The following is a description of a gene set: Genes down-regulated in comparison of unstimulated CD8 T cells at 48 h versus CD8 T cells at 48 h after stimulation with IL12. species: Homo sapiens Human Gene Set: GSE15930_STIM_VS_STIM_AND_IL12_48H_CD8_T_CELL_DN from publication Agarwal P, Raghavan A, Nandiwada SL, Curtsinger JM, Bohjanen PR, Mueller DL, Mescher MF (PMID 19592655) Differentiation of naive CD8 T cells into cytotoxic effector cells requires three distinct signals- antigen (signal 1), costimulation -B7-1 (signal 2) and cytokine, either interleukin-12 or interferon-a/b (signal 3). Interaction of naive CD8 T cells with antigen and B7-1 programs cell division and proliferation whereas the presence of cytokines- IL-12 or IFNa/b promote survival, differentiation and memory establishment. In the absence of signal 3, the cells interacting with antigen/B7-1 undergo tolerance induction. The objective of this study was to elucidate the mechanisms how the provision of signal 3 promotes differentiation and averts tolerance induction in CD8 T cells. Trichostatin A is a pharmacological agent that inhibits histone deacetylase activity, hence regulating chromatin structure and gene expression and differentiation in many cell types. Gene signature profiles of IL-12, IFNa/b and trichostatin A stimulated cells were compared to elucidate the molecular mechanisms of gene regulation. Oligonucleotide microarray analysis is carried out to determine the extent and molecular nature of the CD8 T cell differentiation program induced by IL-12 or IFNa/b in concert with antigen and B7-1 signal., and this is the list of marker genes: TNFSF10, ADRB2, ERCC4, GTF2F2, EPS8, TACSTD2, SOCS3, HRAS, GP1BA, HOPX, RAN, ANXA10, POLD2, SURF1, TMEM41B, FABP5, CASP4, ZNF239, GPR65, MT3 (metallothionein 3), ADAM8, FURIN, IL6, B4GALNT2, PGS1, H19, SQOR, IL18R1, PTPRK, ALAD, GATM, PLA2G12A, IL15, CRABP2, PGAM1, CCR5, MYD88, IGF2BP2, GPAT4, TMOD3, TASOR, TAF1D, BCL3, PRDM1, IL1RL1, RBPJ, MID2, IL2RB, CDS2, AHRR, YIPF4, S100A11, SERBP1, UBA5, ARL5A, NKAIN1, PRNP, MTMR7, KSR1, ADORA2A, KLF7, PLS3, GNG2 (NCBI Gene Id 54331), NID2, ST3GAL6, IKZF4, GGH, BAX, PLEKHA5, MMS19, CRYBG1, FKBP4, CHD7, CD93, PRR5, FAH, EHD1, DSTN, SERPINB9, SATB1, STX7, GPN2, PRF1, LSS, LDAF1, ABCB9, G3BP1, CSDE1, RHOB, CCND3, TAX1BP1, LGALS3, POLR2C, IL12RB2, ZMAT3, TSG101, KLRC1, CTNNA1, ASIP, CLDND1, ST7, SLCO3A1 (solute carrier organic anion transporter family member 3A1), IFNG, TEX9, SIRT3, PLAC8, SIRT2, YWHAE, CCR2, CACNB3, CASP6, ACTG1 (actin gamma 1), ABCB10, LYSMD2, GIMAP4, NAB1, BDNF, SLC7A11, GNPDA1 (NCBI Gene Id 9930), MAP3K8, IFITM3, S100A1, RWDD4, NEDD4L, SPOP, VPS37B, RRAD, GCNT1, OAT, SELP, SLK, CIAO2B, PFDN1, PADI2, DDX17, DGAT1, NEDD4, FLOT1, RFK, PIM1, COL5A2, TNFSF4, RNF19B, ACYP2, SPATS2, LRBA (LPS responsive beige-like anchor protein), EMP1, CYTIP, HERPUD1, USP18, ACE, JUN, ST6GALNAC4 (ST6 N-acetylgalactosaminide alpha-2,6-sialyltransferase 4), CALR, IRX3 (iroquois homeobox 3, NCBI Gene Id 79191), ANKRD28, NTHL1, GADD45G, LDHA, LHX8, CISD1 (CDGSH iron sulfur domain 1), ACSL1, GNGT2, FASLG, MT2A, SKAP2, EIF2AK3, SH2D2A, P2RX4 (NCBI Gene Id 5025), SUB1, CPOX, LPP-AS2, RNF11, B3GALNT2, PTPN22, SCOC, DBF4, PTTG1, GZMB, KIT, LPP, SLC27A2, S100A6, BATF, GJA1, JARID2, STAT5A, TRAF4, TIMM10 (NCBI Gene Id 26519), TULP4, MMP10, GEM, SSRP1, ABCA1 (ATP binding cassette subfamily A member 1), PDIA6, NDUFS4, IL7R, SGCG, ATP13A2, TMEM165